Given this list of marker genes ADORA2A, MTNR1B, GABRB3, GHRH, FXR1, KCNA2, BTBD9, CSF2, PARP1, CRH (NCBI Gene Id 1392), NPY2R, GHRL, PER3 (period circadian regulator 3), GHRHR, PTGDS, ADRB1, DRD2, ADORA1, NMU, CHRNB2 (cholinergic receptor nicotinic beta 2 subunit), PLN, here is a description of the gene set: The part of the circadian sleep/wake cycle where the organism is asleep. Human Gene Set: GOBP_CIRCADIAN_SLEEP_WAKE_CYCLE_SLEEP species: Homo sapiens